Given this list of marker genes TWSG1, GSTM1, CNTNAP1, ZNF395, DAB2, SLC44A1, MAGED1, GABARAPL1 (GABA type A receptor associated protein like 1), GSN, SHROOM3, KMT2E, SFRP2, SLC12A9, NUDT14, RIN2, ACBD4, WARS1, AZI2, AP3B1, TMEM176B, CTNNBIP1, NME1, NID2, STAT3, ANAPC1 (anaphase promoting complex subunit 1), ENPP4, CCDC80, BET1L, EFNA5, ARNT, ADIPOR2, PNRC1, GOLM1 (golgi membrane protein 1), PKHD1L1, DUSP18, TBC1D2B, XIAP, CTSZ, MTUS1, VAMP8, DENND4C, ADO, TMEM98, ISYNA1, C4B (complement C4B (Chido/Rodgers blood group)), TPMT, COL6A1, PLAT, ID2, SERINC3, GSTM5, HMGN2, F11R, EPHX1, EZR, TBCEL, MLLT6, PLXNB2, GLUL, ATP5IF1, TGM2, S100PBP, MAOA, NOD1, SMARCA2, MGAT3, WT1, ID3, STMN1, CDKN2C, BBX, ADAM10, CTDSP2, H2AZ2, TMEM59, TIMP2, PTPN13, GAS1, IAH1 (NCBI Gene Id 285148), TLE5, ALAD, EMC2, PCNA, SCP2, PARD6B, DBI, RGS8, GATA6, DUSP8, SLC10A6, POLR2A, PAIP2, DCAF8 (DDB1 and CUL4 associated factor 8), SESN1, TMBIM6 (transmembrane BAX inhibitor motif containing 6), APPL2, SUPT6H, NPC2 (NCBI Gene Id 10577), SLC48A1, CRIP1, FTH1, CXADR, SYNE2, SSX2IP (SSX family member 2 interacting protein), NHERF1, SMPDL3B, FAM234A, KCND3, MGST1, ACAA2, SIKE1, CTSB, COPZ2, ID1, GRN, SYT11, TNIP1, RGS10 (NCBI Gene Id 6001), ILDR2, RNF11, NDFIP1, WBP2, CCNL2, TRIM24, MAF1 (MAF1 homolog, negative regulator of RNA polymerase III), GRINA (glutamate ionotropic receptor NMDA type subunit associated protein 1), IGFBP4, WWTR1, DCN, H1-0, ACTN1, GRIA2, BLOC1S1, ADD3, SCHIP1, BNIP3L, FUT8, LY6E, PIK3R1, PSME2, NREP, DCTN6, NET1, MXD4, STMN2, KCNC4, TMC5, UPF3B, OSBPL9, BEND4 (BEN domain containing 4), ZNF780B, MET, NEAT1 (NCBI Gene Id 283131), RASL11A, GDI1, TPI1, NLGN2, CCNI (cyclin I), GABARAP, NBR1, MAN2B1, RSRP1, AGAP1, DNAJA1, STARD4, CD2AP, TLCD3A, TMEM132A, TECR, CST3, ZFP36L1, LEPROT, PDGFRA, B3GAT1, DAG1, SH3BGRL, CHP1, SLC39A10, NPNT, TXNDC12, LAMP2, ING4, MAT2B, DNMT3A, ATP6V1F, SLC16A1 (solute carrier family 16 member 1), CTSA, GAA, ITM2B, TNRC6B, USP25, ALCAM, BSG, LAMA5, NFIA, here is a description of the gene set: from publication Karlsson G, Liu Y, Larsson J, Goumans MJ, Lee JS, Thorgeirsson SS, Ringnér M, Karlsson S (PMID 15769904) Genes down-regulated by TGFB1 in MEF cells (embryonic fibroblast) via TGFB1R. Transforming growth factor-beta1 (TGF-beta) regulates cellular functions like proliferation, differentiation, and apoptosis. On the cell surface, TGF-beta binds to receptor complexes consisting of TGF-beta receptor type II (TbetaRII) and activin-like kinase receptor-5 (Alk5), and the downstream signaling is transduced by Smad and MAPK proteins. Recent data have shown that alternative receptor combinations aside from the classical pairing of TbetaRII/Alk5 can be relevant for TGF-beta signaling. We have screened for alternative receptors for TGF-beta and also for gene targets of TGF-beta signaling, by performing functional assays and microarray analysis in murine embryonic fibroblast (MEF) cell lines lacking Alk5. Data from TGF-beta-stimulated Alk5(-/-) cells show them to be completely unaffected by TGF-beta. Additionally, 465 downstream targets of Alk5 signaling were identified when comparing Alk5(-/-) or TGF-beta-stimulated Alk5(+/+) MEFs with unstimulated Alk5(+/+) cells. Our results demonstrate that, in MEFs, TGF-beta signals exclusively through complexes involving Alk5, and give insight to its downstream effector genes. species: Mus musculus Human Gene Set: KARLSSON_TGFB1_TARGETS_DN